Given this list of marker genes MCCC1, PDZD11, PCCB, HLCS, ACACB, PC, BTD, PCCA, ACACA, SLC5A6, MCCC2, here is a description of the gene set: part of: Metabolism of water-soluble vitamins and cofactors Reactome Pathway: Biotin transport and metabolism species: Homo sapiens Biotin (Btn) is an essential cofactor in a variety of carboxylation reactions. Humans cannot synthesize Btn but it is abundant in the human diet and can be taken up from the intestinal lumen by the SLC5A6 transporter. Its uptake, intracellular translocation, covalent conjugation to apoenzymes, and salvage are described here.